The following is a description of a gene set: The series of molecular signals initiated by nodal protein binding to an activin receptor on the surface of a target cell, and ending with the regulation of a downstream cellular process, e.g. transcription. species: Mus musculus Mouse Gene Set: GOBP_NODAL_SIGNALING_PATHWAY, and this is the list of marker genes: Dact2, Dact1, Cited2, Tgif2, Tgif1 (TGFB-induced factor homeobox 1), Acvr1b, Smad2, Cripto, Smad3, Dand5, Acvr1c, Cfc1, Nodal, Zic2, Lefty1, Dmrt1, Nog